Given this list of marker genes COPS8, CLSPN, ITGB1BP1, NRG1, TPX2, STK11, PRKCD, STRADB, IGF1, CALCA, ADCY8, TNFRSF10B, ZFP91, JAK2, PILRB, ABL1, TLR3 (toll like receptor 3), STRADA, RIPK3, CCDC88A, FBN1, PTK2B (NCBI Gene Id 5748), TOM1L1, CARD10 (caspase recruitment domain family member 10), PRLR, CARD14, CHI3L1, PPIA, ANGPT1, FGF1, TNFRSF10A, GAS6, DYNAP, PIBF1, MT3, ECT2 (epithelial cell transforming 2), TNFSF15, TRAF6, TLR6, KIF14, LEP (NCBI Gene Id 3952), here is a description of the gene set: Any process that initiates the activity of an inactive protein kinase. studied in species Homo sapiens Human Gene Set: GOBP_ACTIVATION_OF_PROTEIN_KINASE_ACTIVITY